Given this list of marker genes TRAF1, BPGM, ZNF277, IL2RG, ETV4, GPNMB, ANXA10, SLPI, GNG11, MALL, TOR1AIP2, TMEM176B, AKT2, NR1H4, RELN, ATG10, MMP10, FCER1G, FBXO4, LAT2, BTC, PTPRR (protein tyrosine phosphatase receptor type R), CFHR2, NR0B2, CA2, USP12, AKAP12, ANGPTL4, PCP4 (NCBI Gene Id 5121), TSPAN7, TRIB2, ETS1, IL7R, PLAT, MMP11, ERO1A, CBL, DCBLD2, PECAM1, BIRC3, SDCCAG8, LAPTM5, HBEGF, ARG1 (NCBI Gene Id 383), CROT, IL1B, F13A1, GALNT3, TMEM158, EPB41L3, EVI5, ALDH1A2, F2RL1, PCSK1N, EPHB2, PDCD1LG2, DOCK2, DUSP6, NAP1L2, WNT7A, ACE, SEMA3B, ABCB1, TLR8, ANO1, VWA5A, IGF2, GABRA3, MAP4K1, SPP1, PRKG2 (NCBI Gene Id 5593), CTSS, ST6GAL1, CXCR4, PRELID3B, NRP1, ETV5, DNMBP, SCN1B, FLT4, PRRX1, ADGRA2, PTCD2, SOX9, HSD11B1, JUP, TMEM100, PLVAP, PLEK2, TNFRSF1B, TMEM176A, ADGRL4, TNNT2, GPRC5B, MAP3K1, PIGR, APOD, STRN, MMP9, MAFB, CCND2, PPP1R15A, LCP1, NGF (NCBI Gene Id 4803), ITGBL1, IL10RA, CCSER2, CSF2, IL1RL2, PPBP, GYPC, ID2, CXCL10, LY96, MYCN, HKDC1, CFH, MPZL2, CLEC4A, MTMR10, SPRY2, SPARCL1, SCG3, PSMB8, H2BC3, TNFAIP3, HDAC9, CMKLR1 (NCBI Gene Id 1240), IGFBP3, SCG5, KLF4, RGS16, PLAU, USH1C, HOXD11, ITGB2, PTBP2, IKZF1, CDADC1, CAB39L, ENG, LIF, CPE, SNAP91, MAP7, ADAM17, C3AR1, WDR33, BTBD3, TSPAN1, GUCY1A1, INHBA, SPON1, ITGA2, ADAM8 (ADAM metallopeptidase domain 8), CBR4, ZNF639 (NCBI Gene Id 51193), RETN, AVL9, RBM4, SATB1, FUCA1, PEG3, BMP2, FGF9, IRF8, EREG, ALDH1A3, IL33, ADAMDEC1, KIF5C, RABGAP1L, CD37, CBX8, PRDM1, EMP1, GFPT2, CCL20, SNAP25, YRDC, GLRX, NIN, CIDEA, MMD, TSPAN13, CSF2RA, TFPI, TPH1, GADD45G, RBP4, KCNN4, ETV1, ANKH (NCBI Gene Id 7995), AMMECR1, PTGS2, G0S2, TRIB1, PLAUR, SERPINA3 (serpin family A member 3), CFB, here is a description of the gene set: Human Gene Set: HALLMARK_KRAS_SIGNALING_UP from publication Liberzon A, Birger C, Thorvaldsdóttir H, Ghandi M, Mesirov JP, Tamayo P (PMID 26771021) Genes up-regulated by KRAS activation. species: Homo sapiens